The following is a description of a gene set: studied in species Homo sapiens Human Gene Set: HP_PROMINENT_CALCANEUS Protruding heel bone, or calcaneus. Prominent calcaneus, and this is the list of marker genes: RAB33B, DYM, MEG3, RTL1, GFM2, CCDC8, ITPR1, SATB2, RSPRY1, DLK1, OBSL1